Given this list of marker genes Lrig1, Rab11fip1 (RAB11 family interacting protein 1 (class I)), Pnp2, Chpt1, Zfp622, Phf20, Eda, Mmd, Rreb1, Wbp11, Caprin1, Iars1, Zmym2, Atp1b4, Desi1, Garem1, Casr, Fbln5, Fbxw7, Wipi2, Klc1, Smim13, Vegfa, Cntnap1, Cbx6, Adamts3, Atf6, Kbtbd2 (NCBI Gene Id 210973), Jarid2, Fmn2, Rbm6, Spsb4, Septin2, Bmpr1a, Ccnd2, Aff4, Tgfbr3, Prrc2c, Sesn1, Sel1l3, Kif1b, Acvr2a, 1700025G04Rik, Dcaf7, Kcnk10, Nos1, Plekhm3, Ccdc85b, Anks1, Ubfd1, Ago1, Arl2, Dixdc1, Mapkap1 (mitogen-activated protein kinase associated protein 1), Stxbp3 (syntaxin binding protein 3), Rere, Sall4, Hmga1, Med1 (mediator complex subunit 1), Ythdc1, Xpo7 (exportin 7), Cacul1, Ist1, Slc20a2, Eya1, Fasn, Rubcnl, Wee1, Ubn2, Nrn1, Cdk5r1, Tbpl1, Fgf9, Tmem135, Lhx3, Sec61a1, Tcaim, Cert1, Ptpn3, Cfap45, Dll1, Znrf2, E2f7, Dync1li2, Dnajc16, Slit2, Atp2b2, Tlk1 (NCBI Gene Id 228012), Pappa2, Tbl1xr1, Htr4, Zfp367, Capns1, Wnk3, Slc4a7, Nufip2, Abl2, Adgrl1, Pafah1b1, Fbxo21, Tenm2, Cdk12, Ankrd33b, Cbfa2t3, Abtb2, Ptprr, Tnrc6b, Nudt4 (nudix hydrolase 4), Phf19, Man2a2, Kl, Ppp6c, Ccr2, Kif5b, Atxn2, Ccne1, Nup210, Usp15, Lurap1l, Cdk17, Plpp1, Kdsr, G0s2, Capn6, Tuba4a, Ccdc6, Med26, B4galt1, Adissp, Lats1, Tmcc1, Ghr, Prdm4, Krtap26-1, Il7r, Csrnp1, Prmt6, Pnoc, Lrrc32, Helz, Arfgap2, Apln, Zfp449, Aar2, Ccnt2, Ppm1e, Zswim3, Tmem74b, Seh1l, Sec14l1, Grm7, Dcp1a, Dennd10, Reck, Cpsf7, Slitrk6, Usp42, N4bp1, Nfatc3, Chd2, Cc2d1b, Slc6a11, Dll4, Hephl1, Amotl1, Wnt7a (wingless-type MMTV integration site family, member 7A), Chac1, Nlrx1, Rasef, Gm12886, Sox6, Avl9, Kcnj2, Pnpla6, Btg2, Atg14, Tacc1, Klc4, Zfhx3, Eif3a, Pik3r1, Gpatch8, Luzp1, Ppp1r11, Nuak2, Cyp26b1, Gm5460, Plxnc1 (plexin C1), Nudt7, Stradb, Rictor, Atp7a, Fgf7, Krtap11-1, Srpra, Clspn, Plcxd2 (NCBI Gene Id 433022), Btrc, Selenoi, Mex3c (mex3 RNA binding family member C), Nup50, Pla2g15, Mybl1, Syde2, Pacsin2, Ppp2r1b, Arih1, Idh3a, Cdc37l1, Cnot6l, Arhgap12, Nol4l, Crebrf, Fam151b, Crebl2, Rnf144b, Ippk, Islr, Cd2ap, Lrig2, Onecut2, Akap11, Lrp6, Usp14, Sema6d, Cacna2d1, Peli3, Smad7, Myt1l, Zbtb44, Igf2r, Bcl2, Colq, Sez6l, Mfn2, Socs6, Tll1, Phc3, Nxph1, Penk (preproenkephalin), Erlin2, Ddx3x, Zfp809, Angel1, Slc13a3, Zbtb39, Nectin1, Cpeb3, Pip4p1, Nav1, Zbtb34, Arhgdia, Spag7, Rnf217, Rad23b, Qki, Plekhh1, Unc80, Ell, Akt3, Plxna4, Epha7, Ncapg2, Ash1l, Kpna1, Slc4a4, Rasgef1b, Dclk1, Sik1, Adrb2, Cobll1, Cpd, Rab10, Map2k1, Ahcyl2, Pou2f1, Omg, Kif21a, Klhl2, Suco, Usp25, Kif5c, E2f3, Zcchc3, Ccnjl, Trank1, Pip4p2, Etnk1, Chek1, Hectd1, Trabd2b, Kctd8, Ezh1, Mlycd, Tab3, Fermt2, Il10ra, Ano3, Actr2, Cdc25a, Slc7a2, Raf1, Armcx6, Mob3b, Myb, Pam, Ski (ski sarcoma viral oncogene homolog (avian)), Gpr63, Bace1, Akap7, Kif1c, Rfc1, Clock, Trp53inp2, Kif23, Cdca4, Sema3a, Spred1, Zbtb43, Scoc, Atxn7l3 (NCBI Gene Id 217218), Ncs1, Dsel, Setd3, Ube2q1, Wnt3a, Usp31, Armh4, Ube4b, Bicd1 (BICD cargo adaptor 1), Sall1, Cops7b, Sptbn2, Phip, Ago4, Bcl2l2, Pdxk, Itpr1, Satb2, Usp12, Nrbp1, Hapstr1, Drd1, Phactr2, Ywhah, Rab9b, Wwp1, Zfhx4, Polr3f, Son, Slc39a10, Tmem178b, Pth, Mgat4a, Plxna2, Col12a1, Rfx3, Axin2, Ankrd13b, Rarb, Prkar2a, Smurf1, Pappa, Entpd7, Traf3, Shoc2, Pwwp2b, Spryd3, Rnf10, Ret, Cpeb2, Gbp2b, Slc25a22 (solute carrier family 25 (mitochondrial carrier, glutamate), member 22), Cmpk1, Higd1a, Sgk1, here is a description of the gene set: Genes predicted to be targets of miRBase v22 microRNA mmu_miR_6419 in miRDB v6.0 with MirTarget v4 prediction scores > 80 (high confidence targets). from publication Chen Y, Wang X (PMID 31504780) Mouse Gene Set: MIR_6419 studied in species Mus musculus